Given this list of marker genes CYP11B2, CACNA1S, KCNE3, CLCN2, MEN1, CYP11B1, SCN4A, APC, CDKN1B, here is a description of the gene set: Human Gene Set: HP_ADRENOCORTICAL_ADENOMA Adrenocortical adenomas are benign tumors of the adrenal cortex. studied in species Homo sapiens Adrenocortical adenoma